Given this list of marker genes PLXDC2, CARD16, GCA, TRIOBP, CYBA, MOB3A, LTA4H, TALDO1, C1orf162, SIRPA, STMP1, EIF4EBP2, MYADM, ADAM9, LENG8, PLA2G7, EREG (NCBI Gene Id 2069), PTAFR, BRI3, TMEM167A, NOD2, ATP5MC2, RASGRP4, TLR8, LTBR, IL1RN, CORO1C, MED13L, SNX27, MFSD1, RASSF4, MMP17, OTULINL, CKLF, COX6B1, PTPRE, GSTP1, PHC2, APBB3, ANXA5, CDA (cytidine deaminase), S100A9, FPR2, NORAD, FPR1, LCP1, MBOAT7, VSTM1, SRGN, SEMA4A, PLAUR, SULT1A1, ACER3, GNAQ (NCBI Gene Id 2776), TRIQK, RBP7, CKAP4, CSGALNACT2, GLIPR1, LPGAT1, CD33, CD1D, SDCBP, KLF7, ATP5ME (NCBI Gene Id 521), SLC11A1, KLF6, JUND, CNPY3, EVI5, TMEM176B, CD300LB, AP1S2, CTSD, CSF3R, ATP5F1D, CATSPER1, CRISPLD2, SIGLEC14, S100A4, CARS2, GNS, LAMTOR4, METTL9, ASGR1, RAB11FIP1, S100A6, SNX10, DAZAP2, CREB5, LINC02723, STK17B, MYH9, ZDHHC20, UQCR11, PELI2, FLNA, PLEC, SCPEP1, PGD, ENTPD1, AGTRAP (NCBI Gene Id 57085), ZNF467, ZFAND5, EEIG2, SAMD4A, IL17RA, PLD3 (NCBI Gene Id 23646), UBXN11, RAB31, CSTA, ATP6V0B, MEFV, JDP2, MTARC1, GASK1B, RTN3, IFNGR1, ADAP1, PLXND1, RIN2, LRP3, RAB21, CLEC5A, RASSF2, STX10, LIN7A, QPCT, IL10RB, GAPDH, S100A8, CD14, ENSG00000233461 (NCBI Gene Id 122526782), LILRA6, ARHGAP26, SPIDR, ATP13A3, FAM200B, MSN, PSTPIP1, ATP5F1E, PRKACA, LINC00482, HLX, KYNU, RAB27A, LY96, PLBD1, PADI4, RNF130, NCF4, LTB4R, AQP9, FGL2, NUP214, SIRPB1, TOM1, CCPG1 (NCBI Gene Id 9236), MTMR11, LINC00937, CMIP (c-Maf inducing protein), ETHE1, IVNS1ABP, CTSH, NAIP, CACNA2D4, PSMB3, CES1, ACSL1, MT-ND3, PGAM1, SERPINB1, UBR4, LRRK2, PTPN12, MANBA, SLC36A4, ETS2 (NCBI Gene Id 2114), TFEC, WLS, AP5B1, ALOX5 (arachidonate 5-lipoxygenase), GAS7, EHBP1L1, TMEM176A, CHP1, PRR13, CHSY1, CLEC4E, LINC02728, METTL22, NDUFB1, GPR27, P2RY13, CDC42EP3, MCEMP1, ITGAM, CREG1, MIR23AHG, HIPK3, NDUFA11, FBXL5, LY86, OGFRL1 (opioid growth factor receptor like 1), ARHGEF40, IRAK3, RBM47, SMARCD3, TMTC2, TKT, OAZ1, ANPEP, PYCARD, SFT2D1, HACD4, HEBP2, ACSS2, NICOL1, SLC24A4, CXCL8, AHNAK, ATP6V1A, FCN1, MBD2, ALDH3B1, CHMP4B, KLF4, FOS, IGSF6, ENSG00000238142, RHOU, FAM120A, AKIRIN2, NDUFS7, MS4A6A, ELOB, SLC2A3, KCNE3, FGD4, AGFG1, TREM1, RHOB, CHMP2A, DPYD, GPAT3, DMXL2, NPTN, MGST1, NRG1, PLPPR2 (phospholipid phosphatase related 2), VNN2, STX11, SH3BGRL3, MSRB1, FOLR3, TLR2, TSPO, VAPA, WDFY3, CPD (NCBI Gene Id 1362), LRP1, TMEM107, BCL6, POLE4, TDRD9, AGO4, SGMS2, CCNL1, GMFG, CFP, EMILIN2 (elastin microfibril interfacer 2), TRIB1, FXYD6 (NCBI Gene Id 93560), CTSZ, CCNY, TYROBP, GABARAP, SOAT1, PTCH2, STAC3 (SH3 and cysteine rich domain 3), PTEN, NFAM1, COX7B, TNNT1, SERPINB2, HEXB, IFI27L2, BST1, ATP5MJ, SULF2, CLEC12A, TGFB1, PGLS, TMEM205, NDUFB5, TPP1, PADI2, BASP1, GLIPR2, ATOX1, JOSD2, SRD5A1, PKM, VCAN, DOCK2, GNAI2, CMTM2, CD93, EIF4E3, RXRA, MIR223HG, S100A12, ALDOA, ZNF516, ABHD5, PYGL, DUSP1, CD44, SMCO4, OSCAR, RNF181, EMB, COX4I1, CAPNS1, DENND5A, BNIP2, OTUD1 (NCBI Gene Id 220213), FES, LILRB3, PROK2, TMEM170B, CD163, ABRACL, PLD1, IQGAP1, GPX1, TYMP, MOB1A, ADAM15, LAMTOR2, LRMDA (leucine rich melanocyte differentiation associated), CD55, RAB3D, SPTSSA, CAPG, FOSL2, APLP2 (NCBI Gene Id 51680), DENND6B, ATP5MG, IRS2, ACTR2, TMSB10, S100P, GLT1D1, SPG21, MPEG1, FAR1, NAGA, STXBP2, PRAM1, CR1, PTGS2, SCAND1, FNDC3B, ADA2, TLR4 (NCBI Gene Id 7099), STEAP4, CYP27A1, SELL, PRNP, LAMP2, QSOX1, CASP1, TNFSF13B, STAB1, EAF1, ZYX, CLEC4D, CYFIP1, INPPL1, WDR26, AGTPBP1 (NCBI Gene Id 23287), CD302, NCF1, MCL1, THBS1, MEGF9 (multiple EGF like domains 9), ANO6, SAMSN1, CEACAM4, MXD1, FRY, RILPL2, OAF, DOK3 (docking protein 3), PRKCB, PRRG4, ATP6AP2, LNCATV, F5, ARL8A, ANXA2, ACTB, RRP12 (NCBI Gene Id 95039), HNMT, AP2S1, FBP1, ANXA1, GM2A, TMBIM4, KIF13A, GAA, PDXK (pyridoxal kinase), TGOLN2, SKAP2, SLC15A3, RGS2, SERF2, NCF2 (NCBI Gene Id 4688), MIDN, DYSF, NFIL3, APOBR, MCTP1, ATP11A, VIM, S100A10, ATP6V0D1, POLR2L, SLC16A3, CYBB, UBE2D1, RAB5IF, QKI, ACSL4, TMED5, ASGR2 (asialoglycoprotein receptor 2), VNN1, LYST, MT-CO1, ATP2A2, VNN3P, GRN, TET2, TIMP2, MNDA, RP2, NLRP12, KCTD12, ATP6V0E1, here is a description of the gene set: from publication Hay SB, Ferchen K, Chetal K, Grimes HL, Salomonis N (PMID 30243574) Human Gene Set: HAY_BONE_MARROW_NEUTROPHIL studied in species Homo sapiens